Given this list of marker genes Slc19a1, Zdhhc9, Tab1, Map3k7, Btk, here is a description of the gene set: species: Mus musculus Mouse Gene Set: GOBP_POSITIVE_REGULATION_OF_CGAS_STING_SIGNALING_PATHWAY Any process that activates or increases the frequency, rate or extent of of cGAS/STING signaling pathway.